The following is a description of a gene set: Human Gene Set: GOMF_DOUBLE_STRANDED_DNA_3_5_DNA_EXONUCLEASE_ACTIVITY species: Homo sapiens Catalysis of the sequential cleavage of mononucleotides from a free 3' terminus of a double-stranded DNA molecule., and this is the list of marker genes: APEX2, TREX1, RAD9A, APEX1, TREX2, RAD1